The following is a description of a gene set: studied in species Homo sapiens Genes up-regulated in comparison of naive CD8 T cells versus exhausted CD8 T cells. CD8 T cells normally differentiate from resting naïve T cells into function effector and then memory CD8 T cells following acute infections. During chronic viral infections, however, virus-specific CD8 T cells often become exhausted. We used microarrays to examine the gene expression differences between naive, effector, memory and exhausted virus-specific CD8 T cells following lymphocytic choriomeningitis virus infection. from publication Wherry EJ, Ha SJ, Kaech SM, Haining WN, Sarkar S, Kalia V, Subramaniam S, Blattman JN, Barber DL, Ahmed R (PMID 17950003) Human Gene Set: GSE9650_NAIVE_VS_EXHAUSTED_CD8_TCELL_UP, and this is the list of marker genes: SLC66A2, TIMM44 (translocase of inner mitochondrial membrane 44), LDAH, XIAP, NSG2, PLAC8, DDC, RNPS1, RERE, UBR4, INTS9, DNAJB1, DYM, TBCEL, SELENOH, C5orf34, C18orf32, HBG2, GIT1, RNASEH2A (NCBI Gene Id 10535), METTL9, ABCE1, PPIF, PHTF1, AURKAIP1, IL7R, KLF2, MAP1LC3B, SLCO3A1, FARSB, GSTT2, NUDT16L1, SNX6, TMEM223, TMEM50B, CHP1, SLC1A5, GHITM, PHETA1, EIF2S1, ANAPC5, TXNL4A, IKBKE, ATP6V0B, LYSMD1, RGS10, RALGPS2, PSMD13, ANTKMT, PWP1, ACADM, CCR7, ATP6V0C, PDE6A, PIK3CD, SNRNP40, TIA1 (TIA1 cytotoxic granule associated RNA binding protein), SETD6, ADD1, MAT2A, HDAC5, SEMA4A (semaphorin 4A), CLK4, JKAMP, AP3M1, RPN1, PSAP, BRAP, LRWD1, RAD17, FBXL3, PIGX, API5, RPP25L, TDRP, ATP8A1, SRCAP, ITGB7, SS18 (NCBI Gene Id 6760), ANAPC16, GSN, SRPK1, KLK8, PIP4K2A, MRPL37, PRKD2, EYA2, CNN3, FAM107B, RAMP1, MBTPS1, PSMC5, S1PR4, RNF38, GM2A, PTPN6 (NCBI Gene Id 5777), FBL, RUFY1, MTCH1, TWF2, NCOA5, IMPDH2, EML5, PRKCB, EIF3B, P4HA1, IFRD2 (NCBI Gene Id 7866), KCNN4, DAP, CDC37, GALNT11, GABBR1, ST13, SEPTIN6, GFUS, CACUL1, HEXA (NCBI Gene Id 3073), RABGGTA, IDH2, CCT4, IPO4, ADRB2, MBP, DNAJC7, GALNT10 (polypeptide N-acetylgalactosaminyltransferase 10), PRPSAP1, YIPF1, USP24, NSMCE1, ENG, C8orf33, HSD11B1, LMAN1, GNPAT (NCBI Gene Id 8443), PKD1, CYBC1, VPS25, GLO1 (glyoxalase I), SMU1, IGHM, MLX, SGK1, RPRD1A, TEC, ORC5, ANKRD10, HPCAL1, UBA2, DUS1L, NDEL1, HADHB, EXOSC7, SRP68, DDX50, HBS1L, CLIP1, EEIG1, SNTB1, MRPS18B, EMB, USP39, GTF2I, YIPF3, ARFGAP2, DGKA (NCBI Gene Id 1606), GGT5 (gamma-glutamyltransferase 5), ISYNA1, RFLNB, CNDP2, DCTN5, EIF2B5, SPTLC1, ITPA, RTCB, DEAF1, B4GALT1, SELL, CCND2, SATB1, MORF4L2, ABLIM1, ACP5, CCNDBP1, PRMT3 (NCBI Gene Id 10196), ABCC5, MAFK, CALU, XPC, PPDPF, ST6GAL1, SESN1, SPNS1, TUBB, ARMC1, RBM38, RNF5, ADCY7, ELOVL5, CCT8, PLP2